Given this list of marker genes ACTN4, ATP1B1, PKP2 (NCBI Gene Id 93271), ATP1B3, CHP1, NOS1, MLLT6, SCN1B, WNK2, SCN5A, FXYD7, FXYD3, FXYD6, STK39, FGF13, FXYD6P3, CNKSR3, FXYD4, SCN3B, SCN2B, FXYD5, CNTN1, ANK3, AKT1, TESC, WNK3, NKX2-5, FXYD1, GPD1L, FGF12, SCN4B, FXYD2, AHCYL1, ATP1B2, PRSS8, here is a description of the gene set: Human Gene Set: GOBP_POSITIVE_REGULATION_OF_SODIUM_ION_TRANSPORT Any process that increases the frequency, rate or extent of the directed movement of sodium ions (Na+) into, out of or within a cell, or between cells, by means of some agent such as a transporter or pore. species: Homo sapiens